Given this list of marker genes Bola3, Ak2, Dpagt1, Ly6d, Ppa1, Fcgr2b, Idi1, Ctnnbl1 (catenin, beta like 1), Mydgf, here is a description of the gene set: from publication Cui A, Huang T, Li S, Ma A, Pérez JL, Sander C, Keskin DB, Wu CJ, Fraenkel E, Hacohen N (PMID 38057668) Genes positively differentially expressed in cell type: pDC (plasmacytoid dendritic cell) upon treatment with cytokine: IL-13 in mouse lymph nodes in vivo. studied in species Mus musculus Cytokines mediate cell-cell communication in the immune system and represent important therapeutic targets. A myriad of studies have highlighted their central role in immune function, yet we lack a global view of the cellular responses of each immune cell type to each cytokine. To address this gap, the authors created the Immune Dictionary, a compendium of single-cell transcriptomic profiles of more than 17 immune cell types in response to each of 86 cytokines (>1,400 cytokine-cell type combinations) in mouse lymph nodes in vivo. A cytokine-centric view of the dictionary revealed that most cytokines induce highly cell-type-specific responses. For example, the inflammatory cytokine interleukin-1β induces distinct gene programmes in almost every cell type. A cell-type-centric view of the dictionary identified more than 66 cytokine-driven cellular polarization states across immune cell types, including previously uncharacterized states such as an interleukin-18-induced polyfunctional natural killer cell state. Mouse Gene Set: CUI_PDC_IL13_RESPONSE_UP